Given this list of marker genes Crp, Pcsk9, Adipoq, Commd1, Anxa2, Il19, Hnrnpk, Csk, Abcc8, Khsrp, Washc1, Cd36, Mylip, Apob, Cnpy2, Scarb1, Apoc3, Ldlrap1, Ehd1, Nr1h4, Lipc, Dgat2, Ldlr (NCBI Gene Id 16835), Trem2, here is a description of the gene set: studied in species Mus musculus The process in which a low-density lipoprotein particle is removed from the blood via receptor-mediated endocytosis and its constituent parts degraded. Mouse Gene Set: GOBP_LOW_DENSITY_LIPOPROTEIN_PARTICLE_CLEARANCE